Given this list of marker genes Ankle2, Trib1, Lrp6, Dus2, Htra2, Nolc1, Pkib, Cib1, Hspa5 (heat shock protein 5), Rptor, Sh3bp5l, Smo, Deptor, Lilrb4b, Cit, Ywhab, Wnk1, Itprip, Chp1, Mbip, Cdkn1c, Camk2n2, Ppef2, Prex1 (NCBI Gene Id 277360), Prkrip1, Casp3, Rhoh, Hexim1, Dnajc3, Qars1, Cdkn2c, Prkar1a, Ankrd42, Pkia, Akt1s1, Trib2, Cdkn1a, Nck1, Prkar1b, Spred1 (NCBI Gene Id 99293), Hspb1, Rack1, Spry4, Ppp2r5a, Cdkn2a, Cdkn1b, Prkag2, Tesc, Inca1, Wars1, Ptprc, Hexim2, Dusp19, Parva, Akt1, Pkig, Trib3, Tsacc, Hyal2, Cav1, Inka1, Pmp22 (NCBI Gene Id 18858), Cep43, Smcr8, Prkch, Pak1ip1, Cdkn2b, Gprc5b, Cdkn2d, Prkar2b, Dusp22, Lilrb4a, Gskip, Spred2, Gckr, Macroh2a1, Atad3a, Socs1, Camk2n1, Socs3, Kat2b, Ibtk, Sh3bp5 (SH3-domain binding protein 5 (BTK-associated)), Inka2, Npm1, Prex2, Socs5, Ahsg, Prkar2a, here is a description of the gene set: Binds to and stops, prevents or reduces the activity of a kinase. studied in species Mus musculus Mouse Gene Set: GOMF_KINASE_INHIBITOR_ACTIVITY